The following is a description of a gene set: studied in species Homo sapiens Human Gene Set: GSE24210_IL35_TREATED_VS_UNTREATED_TCONV_CD4_TCELL_UP Genes up-regulated in T conv cells: IL35 treated versus untreated. Regulatory T cells (Tregs) play a critical role in the maintenance of immunological self-tolerance. Naïve human or murine T cell treatment with the inhibitory cytokine IL35 induces a regulatory population, termed iTR35, that mediates suppression via IL35, but not IL10 or TGFβ, neither express nor require Foxp3, are strongly suppressive in five in vivo models, and exhibit in vivo stability. Treg-mediated suppression induces iTR35 generation in an IL35- and IL10-dependent manner in vitro, and in inflammatory conditions in vivo in Trichuris-infected intestines and within the tumor microenvironment, where they appear to contribute to the regulatory milieu. iTR35 may constitute a key mediator of infectious tolerance and may contribute to Treg-mediated tumor progression, and ex vivo-generated iTR35 may possess therapeutic utility. from publication Collison LW, Chaturvedi V, Henderson AL, Giacomin PR, Guy C, Bankoti J, Finkelstein D, Forbes K, Workman CJ, Brown SA, Rehg JE, Jones ML, Ni HT, Artis D, Turk MJ, Vignali DA (PMID 20953201), and this is the list of marker genes: PSTPIP2, XAB2, FRAT1, GIGYF1, ALDH16A1, PPP2R3A, ARID4B, TWSG1, ARHGAP29, ZBTB1, CDH7, ADIPOQ, RAB3IP, SPP1, PTGER1, TMEM14A, POLR3B, DSE, COMMD4, HTR1F, FRMPD1, CNRIP1, EGR2, LOXL2, SRSF12, CCKBR, MLLT10, FOXN3, ITGA6, FAM98B, IMMT, NDFIP1, ANKRD9, VSIR, FAM53B, TAGAP, CAMK2D, RALY, PDS5A, TBC1D25, GK, SMG8, GBX1, EXOSC10, KANK3, RAB11FIP1, SPIB, TGIF1, TRPC5, CCDC85A (NCBI Gene Id 114800), BNC2, LIMK2, GRAMD1C, PRUNE1, NSMAF, LCN2, MYBPC2 (NCBI Gene Id 9115), C5orf24, MED29, HNRNPUL2, IGF1, EFHD2, SSBP2, ILF3, IPCEF1, ARL1 (ADP ribosylation factor like GTPase 1), PGP, MINDY2, ZNF217 (NCBI Gene Id 7764), TENT4A, BMPR2, ZBTB11, VWC2L, TET2, LRRC58, ERF, NAIF1, MITF, HOXA4, NDUFS3, FHIP1A, TARBP2, APOE (NCBI Gene Id 99), UBXN6, COA7, GLRB, CNGB3, KIF2A, CLPB, MAK16, CILK1, NANOG, METTL25, NOCT (NCBI Gene Id 25819), PPIP5K2, ANGEL2, KIF18A, RILPL2, ZNF397, FMR1, DKK1, PTK6, PRR32, BCL10 (NCBI Gene Id 8915), PABIR1, ARHGEF3, ADAM10, GZMK, USP42, ADO, PDLIM5, IGSF9, LSM6, IRAG2, CNOT4, MLLT1, SLC38A2, CFAP20, OPTC, H2BC13, SRD5A2, CNNM3, CTSO, HSPA4L, CBFB, GLCCI1, RAB5C, RANBP2, MACIR, CEP44, NDUFAF1, SNX1, MDC1, AZGP1, SEPTIN7 (septin 7), KRT10, ACTN1, EHD1, WASL, NPC2, BAG1 (BAG cochaperone 1), SIRPA, FOXO4, SOX30, PBRM1, GRAMD2B, PRR14L, WHAMM, FRAT2, SLC25A26, RAB3B, UCHL1, EPHX1 (NCBI Gene Id 2052), KLHL20, DNMT3A, NKX2-2, CFTR, DDX54, MTF2, OTUD1, CRY1, IGF1R, BRINP1, GCOM1, FBXO4, ARHGEF6, CNKSR3, DHX38, PMS2, CYP1A2, HDHD2, ADGRV1, TLE4, ABCA6, CERS2, GREM1 (NCBI Gene Id 7947), AP5S1, CCNA1, SLC6A12, TMTC4, KIAA0513, FGF13, TRIM8, RBFA, SPATS1, CDC42EP2, TIMM29, SGK1, MTMR14, CALCOCO1, IFNG, MYO1E, HDAC1, BHLHA9, NCF1, FBXO44, MAN2A2 (NCBI Gene Id 55485), STOML3, MYB